Given this list of marker genes PMEL, NSG2, CHMP6, RAB27B, CHMP5 (charged multivesicular body protein 5), ABCA3, CHMP1B, NDFIP2, CD63, ATP13A2, SORL1, CHMP4C, CHMP2B, CHMP1A, CHMP3, TMEM9, CD300LG, CHMP4B, ABCB6, CHMP4A, GIMAP5, CHMP2A, SLC9A8, LAPTM4B, CHMP7, CHMP4BP1, NSG1, RAB27A, HGS, here is a description of the gene set: species: Homo sapiens Human Gene Set: GOCC_MULTIVESICULAR_BODY_MEMBRANE The lipid bilayer surrounding a multivesicular body.